The following is a description of a gene set: species: Mus musculus Mouse Gene Set: REACTOME_FORMATION_OF_THE_CORNIFIED_ENVELOPE Formation of the cornified envelope, and this is the list of marker genes: Rptn, Pkp2 (NCBI Gene Id 71741), Krt13, Krt34, Krt71, Klk5, Krt35, Dsc2, Gm5414, Spink6, Gm36368, Pkp1, Krt8, Krt25, Krt19, Krt74, Klk12 (kallikrein related-peptidase 12), Cdsn, Krt87, Sprr3, Krt14, Krt86, Krt12, Gm5478, Pkp4, Krt6b, Krt39, Krt23, Krt75 (NCBI Gene Id 76250), Krt9, Lipn, Krt4, Jup, Krt85, Krt26 (keratin 26), Ppl, Krt10, Klk8, Krt73, Krt15, Krt31, Krt33a, Krt2, Lipm, Krt27, Tgm1, Cela2a, Pkp3, Krt32, Dsp, Stfa2l1 (stefin A2 like 1), Krt82, Krt16, Dsg2 (desmoglein 2), Krt18, Krt5, Kazn, Casp14, Stfa2, Krt83, Krt78, Klk13, Krt17, Dsc1, Krt80, Evpl, Krt28, Krt79, Tchh, Krt1, Krt76, Klk14, Krt36, Dsg3, Spink5, Perp, Lipk, Krt40, Dsg4, Krt33b, Dsg1a, Krt7, Krt6a, Krt77 (NCBI Gene Id 406220), Krt81, Krt24, Krt72, Dsc3, Krt84, Krt20